Given this list of marker genes CPNE8 (NCBI Gene Id 144402), FRMPD4, SYT7, APOC1, DYSF, WDFY3, WDPCP, UCP1, GPR119, ANXA7, RUBCN, PICK1, CGAS, RAG2, RUBCNL, PIK3C2A, RASA2, PIK3C2B, RAB35, ARAP1, RLBP1, CLN6, PLEKHA8P1, SYT14P1, LANCL2, AIDA, PIGK, PACSIN1, NLRP3, JPH2, SH3PXD2A, PCTP, PFN1, ANXA8L1, PLA2G4C, SPTBN4, TTPAL, OGT, DEFB4A, SLC9A3, LPAR4, BLTP2, DGKA, APPL1, TPCN2, VDAC1, SYT17, ARFIP2, ITPR1, CD300A, ANXA4, CPS1, TNFAIP8L3, DOC2B, RPH3A, SVIL, RBSN, RASGRP1, PSD2, TIRAP, GRK5, WNT5A, LPAR3, THBS1, DPEP1, ZFYVE28, APOA1, LPAR1, CPNE3, FUZ, KCNH1 (potassium voltage-gated channel subfamily H member 1), PLEKHF2, PLA2G4D, SNX10, BTK, IQGAP1, ANXA10, GSDMB, SNX21, GABARAPL3, ALOX15, PIK3C2G, STAM, VAMP2, FZD7, MME, PCLO, PON1, WASHC2A (NCBI Gene Id 88731), GAP43 (NCBI Gene Id 2596), SGIP1, ADAP1, HIP1R, PLA2G2D, PLA2G5, GGA3, NME4, ARL6 (NCBI Gene Id 84100), GAB2, SNX2, MREG, SYTL2 (synaptotagmin like 2), F3, CAVIN2, GSDME, PLA2G2F, ANXA13, PXDC1, PITPNM2, TEC, ARHGAP44, ANXA2P2, NUP35, ABCA1, CPNE1, GAS6, GLTPD2, NRGN, SHC1, RASA4, SNX17, SBF2, WDFY1, ESYT1, PSD, CARMIL2, TOM1L1 (NCBI Gene Id 10040), ITPR3, PLTP, SYT15, SMPD3, ARAP2, SDCBP, UNC13B, NOXO1, SNCA, TULP3, NCF1B, SNX18, SNX27, SMURF1, PITPNM1, BAD, WASHC2C, NR5A2, ARHGAP33, BIN1 (bridging integrator 1), MARK1, MFGE8, SNX14, FCGR3B, APOA2, ATP13A2, PTAFR, FAAH, DNM2, OTC, KCNJ3, SPTBN2, ARHGAP9, GOLPH3L, AVIL, PLA2G15, CIDEA, TWF1, APOH, PLEKHA1, PITPNA, GABARAP, RNF34, NUMA1 (NCBI Gene Id 4926), RPE65, F10, C2CD2L, AMER2, ARHGAP26, OC90, PLA2G7, FES, BPIFC, AGAP1, RUFY4, BSCL2, MYO10, INTU, BAIAP2L2, MAP1LC3C, CPNE7, SYT6, PASK, SNX24, HS1BP3, PPT1, SNX16, SCIN, FCHO2, APOM, FCHSD2, WIPI1, PHLDA3 (pleckstrin homology like domain family A member 3), PXK, FLII, ANXA8, EXOC7, PLA2G4E, KCNQ1, SDCBP2, PLEKHB2, ZCCHC2, RAPGEF2 (NCBI Gene Id 9693), KCNJ2, CCDC88A, EEA1, NCF4, GSDMA, MCF2L, SEPTIN12, PITPNB, AMPH, PLA2G4F, GLTP, NUP62, FUNDC2 (NCBI Gene Id 65991), ARAP3, APOC3, PFN2, SNX5, RASA4B, HIP1, CHMP2A, GRAMD2A, CIBAR1, OSBPL8, PLEKHA3, PLA2G2E, GRB7, AMER3, DEPTOR, MTM1 (myotubularin 1), NISCH, CD300LF, UQCC3, TULP1, NR5A1, ANXA5, ZFYVE19, SCARB1, SNX4, TREM2, EXOC1, SNX29 (NCBI Gene Id 92018), CETP (cholesteryl ester transfer protein), PLCB1, BBS5, DAPP1, SAP30L, MCTP2, ADGRB1, OBSCN, JCHAIN, PSD4, SYT8, TWF2 (twinfilin actin binding protein 2), EPDR1, ZFYVE9, STOML2, MAP1LC3B, DAB2IP, CYTH3, CLVS1, C2CD5, PLEKHA4, SNX31, IQGAP2, DNM1, OSBP, SNX32, SNX15, GPAA1, LDLRAP1, MCTP1, SYTL4, TLN1, MAP1B, PAFAH2, PEBP1, KRIT1, BCAS3, SNX11, OSBPL2, PARD3B, CLVS2, CFL1, IRGM, ARFIP1, SNX25, FERMT2, APOA4, MITD1, SYT2, MYCBPAP, IGHM, ING2, EPN1, SH3YL1, PIRT, PITPNC1, PLD1, TRIM72, CPNE6, SYT3, SNAP91, GRAMD1B, SNX3, ZCCHC14, OPA1, PHLDA1, SNX7, OSBPL5, SNX12, TTPA, MYO1E, WDR45B, WIPI2, ESYT2, CIDEB, DENND1C, STAP1 (signal transducing adaptor family member 1), SNX19, UNC13C, ANXA6, OPHN1, CPNE9, DOC2A, SNX1, SNX20, SERPINA5, PCYT1B, TECPR1, WDR45, SNX8, SNX9, PRKCI, NF1, TOM1, RASAL1, ZFYVE26 (NCBI Gene Id 338378), MTSS2, SYT1, JAG1, AMER1, VEPH1, APPL2, BIN2, TOM1L2, ITPR2, UNC13A, SYT13 (synaptotagmin 13), SYTL5, PLA2G1B, CPNE4, SESTD1 (NCBI Gene Id 91404), ATG2B, RACGAP1, ANXA11, ZFYVE1, GLE1, AXL, PLEKHN1, PLCZ1, SLC9A1 (solute carrier family 9 member A1), EPB41, CLINT1, DOK7, SCARB2, SYT10, PCYT1A, MYO1G, ABCG1, SYT5, OSBPL10, AKT1, ARHGAP35, EXOC8, MAP1LC3B2, CHMP3, SNX33, RPS6KC1, SH3PXD2B, NCF1C, GSDMC, PLEKHA8, SNX13, VDAC2, SEC14L2, HAVCR1, OSBPL1A, GPR12, ANXA1, PLEKHF1, PLCD1, ANXA9, NCF1, SYT4, PLA2G4A, MAP1LC3A, EPN3, EPN2, MTSS1, APOA5, CPNE2, SYT12, APOE, RS1, VILL, CIDEC, SYT14, HGS, ATG2A, ATP8B1, CPTP, TIMD4, KIF16B, ADAP2, MAPT, TRPV1, FGD2, SPTBN1, RAPGEF6, PSAP, PLEKHA5, GSDMD, ARHGAP32, PLEKHA2, SYTL3, MYOF, FRMPD2, PACSIN2, GBF1, CPNE5, VIL1, ANKFY1, PLA2G4B (phospholipase A2 group IVB), THY1, SNX22, VPS36, GGA2, PNPLA3, LAPTM4B, SYT11, ACTN2, GSN (NCBI Gene Id 2934), SNX6, ZFYVE16, PLA2G2A, ULBP2, TPCN1, VPS13B, PIGT, GOLPH3 (golgi phosphoprotein 3), GABARAPL2, PACSIN3, PICALM, CEACAM5, PIGU, BAIAP3 (NCBI Gene Id 8938), ESYT3, MAPKAP1 (NCBI Gene Id 79182), TPP1, PREX1, PLD2, TRPM3, CAPG, SPATA18, GGA1, CERT1 (NCBI Gene Id 10087), C8orf44-SGK3, SNX30, APOB, HMGB1, PHF12, MICALL1, PLEK2, SYT16, COMMD1, MYO1B, PLCB2, STAM2, ANXA3, HCN1, KCNJ1, SYT9, GABARAPL1, DENND1B, PHLDA2, PARD3, SGK3, ANXA2, ENTHD1, PLA2G10, DENND1A, PLA2G2C, RCSD1, here is a description of the gene set: species: Homo sapiens Binding to a phospholipid, a class of lipids containing phosphoric acid as a mono- or diester. Human Gene Set: GOMF_PHOSPHOLIPID_BINDING